The following is a description of a gene set: Regulatory CD4+ T cells (Tr cells), the development of which is critically dependent on X-linked transcription factor Foxp3 (forkhead box P3), prevent self-destructive immune responses. Despite its important role, molecular and functional features conferred by Foxp3 to Tr precursor cells remain unknown. It has been suggested that Foxp3 expression is required for both survival of Tr precursors as well as their inability to produce interleukin (IL)-2 and independently proliferate after T-cell-receptor engagement, raising the possibility that such 'anergy' and Tr suppressive capacity are intimately linked. Here we show, by dissociating Foxp3-dependent features from those induced by the signals preceding and promoting its expression in mice, that the latter signals include several functional and transcriptional hallmarks of Tr cells. Although its function is required for Tr cell suppressor activity, Foxp3 to a large extent amplifies and fixes pre-established molecular features of Tr cells, including anergy and dependence on paracrine IL-2. Furthermore, Foxp3 solidifies Tr cell lineage stability through modification of cell surface and signalling molecules, resulting in adaptation to the signals required to induce and maintain Tr cells. This adaptation includes Foxp3-dependent repression of cyclic nucleotide phosphodiesterase 3B, affecting genes responsible for Tr cell homeostasis. Cluster T4 of genes with similar expression profiles in thymic T lymphocytes after FOXP3 loss of function (LOF). species: Mus musculus Human Gene Set: GAVIN_FOXP3_TARGETS_CLUSTER_T4 from publication Gavin MA, Rasmussen JP, Fontenot JD, Vasta V, Manganiello VC, Beavo JA, Rudensky AY (PMID 17220874), and this is the list of marker genes: NOD1, P2RX7, ITGB1, CAPG, SELENOK, GPRIN3, HINT1, ADSS2, PSMD8, NT5E, RNH1, ATP10D, CD44, SLC30A7, SOCS2, GUCY1A1, OTULIN, YWHAQ, IL2RA, ODC1, HIPK1, RPN2, PSMB3, SH3BGRL, RRAGD, MYC, IKZF2, AHNAK, RORA, IGF1R, CTLA4, GLUD1, ENDOD1, IL2RB, METTL17, ETFBKMT, WLS, MTHFS, GPX4, CALHM6, CD48, LARP1B, NRP1, PENK, PLAAT3, NIBAN1, XBP1, SMPDL3A, ARF1, STON1, TRBV11-3, CD38, PLEKHB2, KARS1, SYT11, APOL1, NOP53, TIMM10, TNFRSF9, IL1R2, STX11, DENND5A, TIAM1, SYNGR2, NUCB2, PPM1L, SNX14, MAF1, SH3BP5, AHCY, ZNF622, SEMA4A, TTC39B, ITGAV, STAT4, FOXP3, PSMD4, ITGAE, SMU1, NRIP1, INPP5F, ANKRD17, SNX18, FAM107B, BTG2, PLSCR1, DRG1, ITGB8, TMEM65, ITGA6, CYFIP1, BMPR2, IRF4 (NCBI Gene Id 4592), LRIG1, SC5D, RESF1, C3orf80